The following is a description of a gene set: Human Gene Set: HP_ABNORMAL_TUBULAR_BASEMENT_MEMBRANE_MORPHOLOGY species: Homo sapiens Abnormal tubular basement membrane morphology Abnormal structure of the basement membrane of the renal tubulus., and this is the list of marker genes: XPNPEP3, MUC1, TMEM67, DCDC2, NPHP1, SEC61A1